Given this list of marker genes KIF5C, SLC3A2, SGK3, GFPT1, PYCR1, SLC33A1, CXCL2, CDT1, CANX, CALR, EIF2AK3, NDUFB3 (NADH:ubiquinone oxidoreductase subunit B3), BMAL1, GADD45A, ASNS, GFAP, TXNRD1, CBR3, CCPG1, FUT1, FKBP2, DNAJB11, KCNF1, TFRC, DDIT4, SEMG1, PRKCZ, PDIA3, ANLN, PPIB, PDIA6, CLGN, PIGA, GSDME, B3GNT6, RRM2, TXNIP, SEPHS2, ART3, TGIF1, GABARAPL3, ELF3, NEU1, PPEF2, PLK3, SARS1, PRAME, RELB, PDIA4, KDELR2, DNAJC3, PREB, H4C11, CDK1, OCLN, ZAP70, TRPS1, SLC35B1 (solute carrier family 35 member B1), PCK2, GOT1, PBK, here is a description of the gene set: Although hypovasculature is an outstanding characteristic of pancreatic cancers, the tumor cells survive and proliferate under severe hypoxic, glucose-deprived conditions caused by low blood supply. It is well known that the hypoxia-inducible factor-1 pathway is essential for the survival of pancreatic cancer cells under hypoxic conditions. To discover how pancreatic cancer cells adapt to glucose deprivation as well as hypoxia, we sought glucose deprivation-inducible genes by means of a DNA microarray system. We identified genes whose expression was enhanced under glucose-deprived conditions at >2-fold higher levels than under normal glucose conditions. Among these genes, asparagine synthetase (ASNS) was studied in detail. Although it is known to be associated with drug resistance in leukemia and oncogenesis triggered by mutated p53, its function is yet to be determined. In this study, we found that glucose deprivation induced the overexpression of ASNS through an AMP-activated protein kinase-independent and activating transcription factor-4-dependent manner and that ASNS protects pancreatic cancer cells from apoptosis induced by glucose deprivation itself. ASNS overexpression also induced resistance to apoptosis triggered by cisplatin and carboplatin, but not by 5-fluorouracil, paclitaxel, etoposide, or gemcitabine. We show that glucose deprivation induces the activation of c-jun NH(2)-terminal kinase (JNK)/stress-activated protein kinase (SAPK) in a mock transfectant but not in an ASNS transfectant. Consequently, an inhibitor of JNK/SAPK decreased the sensitivity of pancreatic cancer cells to apoptosis by glucose deprivation and CDDP. These results strongly suggest that ASNS is induced by glucose deprivation and may play a pivotal role in the survival of pancreatic cancer cells under glucose-deprived conditions. Human Gene Set: CUI_GLUCOSE_DEPRIVATION Representative genes up-regulated in MiaPaCa2 cells (pancreatic cancer) under glucose-deprived conditions. from publication Cui H, Darmanin S, Natsuisaka M, Kondo T, Asaka M, Shindoh M, Higashino F, Hamuro J, Okada F, Kobayashi M, Nakagawa K, Koide H, Kobayashi M (PMID 17409444) species: Homo sapiens